The following is a description of a gene set: Any process that activates or increases the frequency, rate or extent of phospholipase C-activating G protein-coupled receptor signaling pathway. species: Homo sapiens Human Gene Set: GOBP_POSITIVE_REGULATION_OF_PHOSPHOLIPASE_C_ACTIVATING_G_PROTEIN_COUPLED_RECEPTOR_SIGNALING_PATHWAY, and this is the list of marker genes: NRXN1, PKD2, GPR27, CHGA (NCBI Gene Id 1113), GRP, F2, RGS2 (NCBI Gene Id 5997)